Given this list of marker genes RPA4 (NCBI Gene Id 29935), PRIM1, PLRG1, POLD4, TONSL (tonsoku like, DNA repair protein), RPA1 (NCBI Gene Id 6117), BCAS2, DONSON, CDC5L, POLD1, PRIM2, HELB, POLA1, SMARCAL1, RPA3, POLD2, RPA2, MCM3, PRPF19, POLD3, POLA2, PCNA, XPA, ERCC5, here is a description of the gene set: Human Gene Set: GOCC_REPLISOME studied in species Homo sapiens A multi-component enzymatic machine at the replication fork which mediates DNA replication. Includes DNA primase, one or more DNA polymerases, DNA helicases, and other proteins.